Given this list of marker genes Notch1, Bmp2, Med28, Ctdp1, Myocd, Dnmt1, Mecp2 (methyl CpG binding protein 2), Smad1, Rgs2, Hdac4 (histone deacetylase 4), Gsk3a, Pi16, Tmem119, Csf1r, Tcf23, Zbed6, Zfp418, Pak1, Rgs4, Nfatc3, Rpl3l, Rcan1, Bhlha15, Prdm6, Plpp7, Hdac3, Tomm70a, Foxo4, Ppara, Sox6, G6pd2, G6pdx, Bmpr2, Bdnf, Ezh2, Daxx, Trim72, Hdac5, Smad4, Bhlhe41, Shh, Ccn3, Ankrd2, Fgf9, Xbp1, Ccnd2, Id2, Msx1, Fzd7, Ptbp1, Nfatc2, Rbpms2, Ereg, Yy1 (YY1 transcription factor), Tnpo2, Nfatc1, Hey1, Dll1, Frs2, Dkk1 (NCBI Gene Id 13380), Igf2, Hey2, Rbm10, Cav3, Pdcd4, Bmpr1a, Foxp1, Ybx1, Pdgfb, Ankrd17, Nkx2-5, here is a description of the gene set: Mouse Gene Set: GOBP_NEGATIVE_REGULATION_OF_MUSCLE_CELL_DIFFERENTIATION Any process that stops, prevents, or reduces the frequency, rate or extent of muscle cell differentiation. studied in species Mus musculus